The following is a description of a gene set: Human Gene Set: KRIEG_KDM3A_TARGETS_NOT_HYPOXIA The hypoxia-inducible transcription factors (HIFs) directly and indirectly mediate cellular adaptation to reduced oxygen tensions. Recent studies have shown that the histone demethylase genes JMJD1A, JMJD2B, and JARID1B are HIF targets, suggesting that HIFs indirectly influence gene expression at the level of histone methylation under hypoxia. In this study, we identify a subset of hypoxia-inducible genes that are dependent on JMJD1A in both renal cell and colon carcinoma cell lines. JMJD1A regulates the expression of adrenomedullin (ADM) and growth and differentiation factor 15 (GDF15) under hypoxia by decreasing promoter histone methylation. In addition, we demonstrate that loss of JMJD1A is sufficient to reduce tumor growth in vivo, demonstrating that histone demethylation plays a significant role in modulating growth within the tumor microenvironment. Thus, hypoxic regulation of JMJD1A acts as a signal amplifier to facilitate hypoxic gene expression, ultimately enhancing tumor growth. Genes not induced under hypoxia, but dependent on KDM3A for hypoxic expression in RCC4 cells (renal carcinoma) expressing VHL. from publication Krieg AJ, Rankin EB, Chan D, Razorenova O, Fernandez S, Giaccia AJ (PMID 19858293) studied in species Homo sapiens, and this is the list of marker genes: METTL3, WDR73, LYRM9, SLC46A3, CRISPLD2, ATP5MK, PFN2, DPH3, TSPAN13, CAPZA1, IRF1, ERFE, TMEM126A, SAA1, NDUFA12, GABARAP, RABEPK, MT-TS2, SEC13 (SEC13 homolog, nuclear pore and COPII coat complex component), LRRC47, PHF11 (NCBI Gene Id 51131), WDR4, B3GNT5, CSTF2, NFS1, ARSB, MMRN2, MRPS18C, B2M, OAS1, IFIT3, BTBD10, STAT4, LGALS8, SPRYD3, VCAM1, COA7, ACTN1, AKAP11 (A-kinase anchoring protein 11), CD47 (NCBI Gene Id 961), GOLGA4, ZNF451, NBDY, PTPN2, PDP1, TUBGCP6, SLC47A2, ACTR6, DYNLT2B, ZNF226, PSMB10, USP13, HPRT1, CLNS1A, THNSL1, NIBAN1, CD40, HMGN2, RTCA, HDHD2, TTC39A, TMEM245, C16orf87 (NCBI Gene Id 388272), ATP9B, HYPK, ATM, TNFSF14, RNF38, LDLRAD3, MMP7 (matrix metallopeptidase 7), PDCD2L, LYPLAL1, NUDT3, EVC, PFDN6, PUF60, PGRMC1, GLMN, GTPBP10, WDR7, PKDCC, TMBIM4, IFI35, VBP1, TMEM106B, STOML1, TMEM254, RBM12, APTX, SGK2, AP1S1, UPP1, COQ3, THRB, URGCP, EIF2A, FKTN, NUPR1, HSDL1, HACL1, CARD16, ATP6AP2, TMEM9B, MTX3, METTL1 (methyltransferase 1, tRNA methylguanosine), TDG, COLEC10, RADX, ALG13, SRSF7, MRPL16, FURIN, ZNHIT6, RPS19, N4BP2L2, FANCL, COX7C, SHISA2, ITGB6, CTSL, IFI44 (NCBI Gene Id 10561), RPUSD3, ALDH1A3, POLR3GL, CYP1B1, AMMECR1, PLA2G4C, LAMC2 (NCBI Gene Id 3918), PSME2, CRELD2, GRAMD2B, EML2, CCDC28B, PAQR3, TMEM128, STAT1, FTH1P12, ASNS, C6orf58, PHACTR2, IL7, SMIM29, POLR1D, VAMP8, EHD1, FKBP5, RRM2B, SLC25A12 (solute carrier family 25 member 12), SIRT5, PRKAB2, SDSL, TMEM140, TAF1D, ZMIZ1, MAT2B, CDC42, EMG1, HIBCH, NOL8, POP4, SLC25A14, ANKRD39, TPM3, TMEM218, MIEN1, SRI, CYCSP55, GBP1, PSMA4, RIOK1, GALNT1, RRAD, ATPAF1, DHX58, PRPF38A, AASDHPPT, LGALS9, RPL36AL, BBS4, C7orf25 (NCBI Gene Id 79020), TMEM216, SAA2, NDUFA5, NEAT1, RPE, GBP3, CDKN1C, SEC11C, CHMP4A, MAGOHB, FABP5P3, FCAMR, ACSL5, EIF2B3, GLO1, SERPINA6, F2RL2, UMPS, NHEJ1, ACOT7 (acyl-CoA thioesterase 7)